The following is a description of a gene set: Genes down-regulated in neutrophil 3d vs 0d in adults (18-49) after exposure to inactivated monovalent influenza A/Indonesia/05/2005 H5N1 split-virus vaccine, time point 3D, administered i.m. BACKGROUND: Vaccine development for influenza A/H5N1 is an important public health priority, but H5N1 vaccines are less immunogenic than seasonal influenza vaccines. Adjuvant System 03 (AS03) markedly enhances immune responses to H5N1 vaccine antigens, but the underlying molecular mechanisms are incompletely understood. OBJECTIVE: We compared the safety (primary endpoint), immunogenicity (secondary), gene expression (tertiary) and cytokine responses (exploratory) between AS03-adjuvanted and unadjuvanted inactivated split-virus H5N1 influenza vaccines. In a double-blinded clinical trial, we randomized twenty adults aged 18-49 to receive two doses of either AS03-adjuvanted (n = 10) or unadjuvanted (n = 10) H5N1 vaccine 28 days apart. We used a systems biology approach to characterize and correlate changes in serum cytokines, antibody titers, and gene expression levels in six immune cell types at 1, 3, 7, and 28 days after the first vaccination. RESULTS: Both vaccines were well-tolerated. Nine of 10 subjects in the adjuvanted group and 0/10 in the unadjuvanted group exhibited seroprotection (hemagglutination inhibition antibody titer > 1:40) at day 56. Within 24 hours of AS03-adjuvanted vaccination, increased serum levels of IL-6 and IP-10 were noted. Interferon signaling and antigen processing and presentation-related gene responses were induced in dendritic cells, monocytes, and neutrophils. Upregulation of MHC class II antigen presentation-related genes was seen in neutrophils. Three days after AS03-adjuvanted vaccine, upregulation of genes involved in cell cycle and division was detected in NK cells and correlated with serum levels of IP-10. Early upregulation of interferon signaling-related genes was also found to predict seroprotection 56 days after first vaccination. CONCLUSIONS: Using this cell-based systems approach, novel mechanisms of action for AS03-adjuvanted pandemic influenza vaccination were observed. TRIAL: ClinicalTrials.gov NCT01573312. studied in species Homo sapiens Human Gene Set: HOWARD_NEUTROPHIL_INACT_MONOV_INFLUENZA_A_INDONESIA_05_2005_H5N1_AGE_18_49YO_3DY_DN from publication Howard LM, Hoek KL, Goll JB, Samir P, Galassie A, Allos TM, Niu X, Gordy LE, Creech CB, Prasad N, Jensen TL, Hill H, Levy SE, Joyce S, Link AJ, Edwards KM (PMID 28099485), and this is the list of marker genes: TSPAN13, MAP6, ANKRD37, TVP23A, DDX21, TTYH2, YBX3, RAVER2